The following is a description of a gene set: studied in species Homo sapiens Human Gene Set: HP_RECURRENT_BRONCHOPULMONARY_INFECTIONS An increased susceptibility to bronchopulmonary infections as manifested by a history of recurrent bronchopulmonary infections. Recurrent bronchopulmonary infections, and this is the list of marker genes: RNF113A, TARS1, MPLKIP (M-phase specific PLK1 interacting protein), USB1, TGFB1, VPS33A, FCGR2A, GTF2H5, GTF2E2, CARS1, ERCC3, ERCC2, AARS1, CFTR, LAMTOR2